The following is a description of a gene set: Human Gene Set: MIR125B_2_3P from publication Chen Y, Wang X (PMID 31504780) Genes predicted to be targets of miRBase v22 microRNA hsa-miR-125b-2-3p in miRDB v6.0 with MirTarget v4 prediction scores > 80 (high confidence targets). studied in species Homo sapiens, and this is the list of marker genes: RAD54L2, AMD1, IL12B, MKRN3, PLEKHA3, SLC7A11, MIPOL1, CTSV, PLPP5, IMMT, VPS50, HACD3, RESF1 (NCBI Gene Id 55196), MED13L, YIPF4, ZIC3, EGLN1, MCHR2, GAD2, YES1, NEGR1, PAX5, BAZ1B, SRFBP1, PRR13, ZCCHC4, FAM131B, DAZAP1, TECPR2, LRATD2, PRPF39, TTC3, MDH1, BRCC3, RTN4R, KRTAP8-1, PCNA, EFCAB11, HPF1 (NCBI Gene Id 54969), TMEM196, PRKCE, PACSIN1, PEG10 (paternally expressed 10), E2F6, GPM6A, PTPN4, EEA1, PDPK1, ELAVL1, ZMYM5, SPTLC2, PDZRN4, GNB4, ZNF585B, PCNX1, POP1, SIRT1, SUDS3, COX7A2, MIS18BP1, ARF6, MXI1, AAK1, EML4, SCML4, MDFIC, CMTM6, HNRNPU, ATP6V1C2, B3GALNT2, SOX8, FRMD6, HMG20A, BCL2L11, GMFB, EFNA5, SLC26A5, PRTG (NCBI Gene Id 650816), DOCK7, BLCAP, GPM6B, CTNS, ASAH2B, EIF3A, PROK2, ZIC2, MKLN1, PRDM16, TRAF3, MFAP1, C11orf87, TPD52L1, CENPC, CPSF6, TENT5A, ANKRD27, ARFIP1, SNRPF, REV1, TCEAL9, NSD3, GRID1, ADCYAP1, CYRIA, USPL1, FAM169A, NEU3, CPEB4, PTGS2, LPAR5, DUSP11, TAF11, GATD1, ECHDC2, VAPA, GABRA4, MYCBP2, TMCC1, CCPG1, GPR85 (G protein-coupled receptor 85), ACTR3, UCHL1, SLC10A7, PPP2CA, RPL9, FBXW2, ERBB4, PSAP, DR1, BMPR1A, CALCR, SEL1L (SEL1L adaptor subunit of SYVN1 ubiquitin ligase), ZNF345, RC3H1, FAM135A